The following is a description of a gene set: Genes having at least one occurrence of the motif TGTGGT in the regions spanning 4 kb centered on their transcription starting sites. This matches the RUNX1 transcription factor binding site V$AML1_01 (v7.4 TRANSFAC). studied in species Homo sapiens Human Gene Set: AML1_01, and this is the list of marker genes: HP1BP3, ARHGAP30, NGB, PLXNC1, RAB30, SYT9, MTX1, PACS1, HHIPL1, XCL1, MSRB3, DENND2D, ITGA10, DDX23, ASCL4, AGO1, TWF1, SUPT16H, RASAL2, HSP90B1, COL4A2, RAG1, APLNR, CARMIL3, RCOR2, RAB39A, CKMT1B, PCGF6, MOAP1, GPATCH2, MYOD1, BICDL1 (NCBI Gene Id 92558), HIVEP3, SEMA4A, DNM3, PRRG4, CELF1 (CUGBP Elav-like family member 1), MAP3K11, SCN8A, FOXN3, TMEM117, LCOR, MPL, S100A9, RILPL1, KCTD4, CSTPP1, RNF19B, PSMA1, BLOC1S1, ANXA8, TSPAN9, CYP17A1, ZBTB25, HOXC6, EMP1, SELENOH, SCN3B, LCK, FCER1G, PYM1, NUCB2, PRICKLE1, ATP6V0B, TNNT2, TACSTD2, MRPL42, TMEM62, NR4A1, SRSF4, BATF, POU2F1, ARNT, JMJD1C, BATF3, BGLAP, IFNG, PDE3B, C1orf198, THBS3, HLX, CREM, KLHDC9, DNASE2B, GPR137B (NCBI Gene Id 7107), ARF3, EMSY, DYNLL1, SGIP1, GTF2A1, NSUN4, DAB1, RABGAP1L, REXO2, LMO3, TACC2 (transforming acidic coiled-coil containing protein 2), ZBTB18, DKK1, ANKRD1, CAP1, LMO2, LRMDA, MADD, MATN1, JDP2, SLC2A3 (solute carrier family 2 member 3), LY9, PXN, LUZP1, TAMALIN, PICALM (phosphatidylinositol binding clathrin assembly protein), TBX5, PLEKHA6, PTPN7, DNHD1, SNX1, WNT8B, BTG4, GRK5, ARHGAP12, TMEM151A, ACIN1, CD6, FAM13C, TLCD5, IL23A, ACSL5, RIN1, VIM, CRTC2, MR1 (NCBI Gene Id 3140), STRC, FGF4, SLC37A4, HDGF, ABCD4, CBL, ARHGEF2, PRR5L, AP1G2, EIF3J, ARHGAP21, RCC2, FRMD4A, TSPAN32, GZMB (granzyme B), TPM1, SPRYD3, SCNN1A, NOTCH2, RGS1, CCDC91, NAV3, EIF2B3, ENTPD1, PAX6, CORO1C, TMCO1, NOTCH2NLA, SIRT1, PHF21A, NHLRC2, PGF, TNFSF4, SLC12A6, NKX2-1, PDZRN4, RGS18, ADAMTS8, SH3BP5L, VRK1, HINFP, SCN2B, NDUFA9, TCF12, COL9A2, KCNJ1, ATF7IP, MIR17HG, RHOG, HIPK1, GPD1, HOATZ, PDZK1, STAT2, CLDN10, TRMT1L, OTOGL, XCL2, RAB5B, MRPS31, SLC37A2, MTMR11, TLL2, C14orf119, VSIG10, CRY1, CADM1, RDH5, HOXC4, SCEL (NCBI Gene Id 8796), FOXD2 (forkhead box D2), ARHGAP32, CHRNA10, NRAS, NRXN3, CALHM3, CALCOCO1, ATN1, SWT1, SLITRK5, KRT74, MDGA2, PIGV, LRP5, SOX5, MIA2, BLOC1S2, TBK1, SPATA17, LINC02694, GRHL3, DNAJC14, ZBTB8A, NFRKB, MMP14, SLC15A3, FGD4, CTSK (NCBI Gene Id 1513), ADAMTS4, CD101, MKRN3, FLI1, TMEM109, DGKA, TMEM86A, KIF1B, KRT73, DACT1, ID3, DIABLO, INTS3, COL4A1, RNF220, EDARADD, ARHGAP42, ANK3, EGR2 (early growth response 2), MSMB, RASGEF1A, GPBP1L1, CRTAC1 (cartilage acidic protein 1), AP5B1, INPPL1, SLC6A9, C11orf42, PTPN22, SMG7, BCAR3, PCF11, UBL3, BMF, AKAP3, ITGB7, CNIH3, MMP13, RORC, ATP2A2, MEIS2, PDE6H, CD69